Given this list of marker genes Smoc2, Hif1a, Cxcr4, Xbp1, Foxc2, Vegfb, here is a description of the gene set: Any process that increases the rate, frequency, or extent of blood vessel formation when new vessels emerge from the proliferation of pre-existing blood vessels and contribute to the series of events that restore integrity to damaged vasculature. species: Mus musculus Mouse Gene Set: GOBP_POSITIVE_REGULATION_OF_VASCULAR_WOUND_HEALING